Given this list of marker genes Bloc1s5, Zeb2, Ppp2cb, Rnf135, Depp1, Cgn, Pou4f2, Ptgr3, Gadd45a, Birc6, Vegfc (NCBI Gene Id 22341), Cdk8, Nbr1, Kat2b (K(lysine) acetyltransferase 2B), Zmiz1, Lrrtm2, Ccn2, Tmem47, Plppr5, Srprb, Eef1a1, Zfp212, Adissp, Tex13b, Cep76, Timp2, Mindy3, Syvn1, Bnip2, Patj, Nxpe3, Scd4, Itgb1bp1, Ebna1bp2, here is a description of the gene set: Mouse Gene Set: MIR_1905 species: Mus musculus from publication Chen Y, Wang X (PMID 31504780) Genes predicted to be targets of miRBase v22 microRNA mmu_miR_1905 in miRDB v6.0 with MirTarget v4 prediction scores > 80 (high confidence targets).